The following is a description of a gene set: species: Homo sapiens Human Gene Set: GOBP_FIBROBLAST_GROWTH_FACTOR_PRODUCTION The appearance of a fibroblast growth factor due to biosynthesis or secretion following a cellular stimulus, resulting in an increase in its intracellular or extracellular levels., and this is the list of marker genes: PTGS2, FGFR1, RGCC, HEG1, MIR152, ROCK2, MIR205 (microRNA 205), MIR195, AIF1, WNT11